The following is a description of a gene set: species: Mus musculus Mouse Gene Set: GOMF_TUMOR_NECROSIS_FACTOR_RECEPTOR_ACTIVITY Combining with tumor necrosis factor, a proinflammatory cytokine produced by monocytes and macrophages, to initiate a change in cell function., and this is the list of marker genes: Tnfrsf18, Tnfrsf1b, Tnfrsf11a, Tnfrsf1a, Tnfrsf4, Eda2r, Fas (NCBI Gene Id 14102)